Given this list of marker genes AFF4 (NCBI Gene Id 27125), ST6GALNAC6, ADORA2A (NCBI Gene Id 135), ACTR2, ARF3, ARNT2, FAM149B1, KIF1B, CRY2, MAP2, GRIN1, RASSF2, KCNH1, ARHGEF2, GNAO1, RALY, CAMK2A, UHMK1, NFE2L1, MXD4, RCC2, SYNGR1, USP2, CALM3, GAD2 (glutamate decarboxylase 2), BPNT2, CHRM1, DNAJB5, HCN2, SSR3, CDH2, CLCN4, ADAR, PSAP, TSPAN5, CHD8, SYT6, BAG6, KIF5A, PRKCB, MYH10, KCNB1, NDST1, MID1IP1, GRIA2, PPTC7, ACP1, ADCYAP1R1, IDS, here is a description of the gene set: Genes up-regulated in the nucleus accumbens (a major reward center in brain) 8 weeks after induction of deltaFosB, a FOSB splice variant. DeltaFosB (a truncated form of FosB) and CREB (cAMP response element binding protein) are transcription factors induced in the brain's reward pathways after chronic exposure to drugs of abuse. However, their mechanisms of action and the genes they regulate remain unclear. Using microarray analysis in the nucleus accumbens of inducible transgenic mice, we found that CREB and a dominant-negative CREB have opposite effects on gene expression, as do prolonged expression of DeltaFosB and the activator protein-1 (AP-1) antagonist DeltacJun. However, unlike CREB, short-term and prolonged DeltaFosB induction had opposing effects on gene expression. Gene expression induced by short-term DeltaFosB and by CREB was strikingly similar, and both reduced the rewarding effects of cocaine, whereas prolonged DeltaFosB expression increased drug reward. Gene expression after a short cocaine treatment was more dependent on CREB, whereas gene expression after a longer cocaine treatment became increasingly DeltaFosB dependent. These findings help define the molecular functions of CREB and DeltaFosB and identify clusters of genes that contribute to cocaine addiction. from publication McClung CA, Nestler EJ (PMID 14566342) Human Gene Set: MCCLUNG_DELTA_FOSB_TARGETS_8WK studied in species Mus musculus